The following is a description of a gene set: studied in species Mus musculus Mouse Gene Set: GOMF_SERINE_HYDROLASE_ACTIVITY Catalysis of the hydrolysis of a substrate by a catalytic mechanism that involves a catalytic triad consisting of a serine nucleophile that is activated by a proton relay involving an acidic residue (e.g. aspartate or glutamate) and a basic residue (usually histidine)., and this is the list of marker genes: Itih5, Itih4, Tmprss11a, Ctsa, Spink5, Masp2, Cela3b, Serpinb1a, Klk1b24, Tpp1, Serpini1, Gzmc, Wfdc18, Klk9, Serpine3, Serpinb9c, Cma1, Serpina3j, Prrg4, Adam17, F3, Clpp, Pcsk1, Dpp8, Col6a3 (NCBI Gene Id 98389), Serpinb5 (serine (or cysteine) peptidase inhibitor, clade B, member 5), Aplp2, Wfdc12, Serpinb9f, Ubac2, C1s1, F2, Klk1b16, Rhbdd2, Mbtps1, Sec11c, Pbp2, Proz, Serpinb3b, Sec11a, Pcsk9, Prss30, C1rl, Klk1b22, Wfikkn1, Cfd, Prss44, Agt, Rhbdf2, F7, Rhbdd3, Serpine1, F12, Prss3, Prss16, Wap, Cfi, Serpina3m, Serpina16, Klk1b1, Klk1b27, Lonp2, Tmprss7, Pebp1, Klk1b9, Serpina1c, Serpinb9b, Slpi, Wfdc21, Prss2, Serpinb11, Rhbdd1, Serpina3i, Prss27, Spink6, Habp2, Tmprss11d, Serpinb9g, Klk11, Wfdc3, Tmprss11e, C1ra, Tmprss9, Prss21, Prss59, Ltf (lactotransferrin), Prss35, Wfdc11, Serpina1f, Cpvl, Gzmk, Rhbdl1, Serpinb7, Parl, Spink8, Klk1b21, Prrg1, Serpinb1c, Pla2g6, Prss54, F9, Acr, Mcpt1, Mansc4, Ache, Mst1, Wfdc5, Spint4, Serpina3f, Rhbdl3, Scpep1, Prep, Tysnd1, Gzma, Serpina3k, Elane, Gzmn, Prss28, Reln, Serpinb3c, Rhbdf1, Prrg2, Hrg, Prss32, Prss42, Pcsk5, Tmprss12, Immp1l, Tmprss6, Tmprss11b, Spink10, Serpinb6a, Prss12, C1rb, Serpinb3a, 1810009J06Rik, Prss39, Prss45, Serpina1d, Prss33, Serpinb13, Tmprss11f (NCBI Gene Id 243083), Itih3, Gzmg, Ctrc, Serpina3g, Spink13, Itih2, Papln, Tpsg1, Wfdc10 (NCBI Gene Id 634952), Htra1, Serpina3c, Serpina3n, Wfdc15b (WAP four-disulfide core domain 15B), Mcpt9, Prss36, Cela1, Prss43, Klk12, Tmprss5, Prss51, Tmprss11g (transmembrane protease, serine 11g), Cd109, Mug2, Prss8, Prss1, Dpp4, Serpinb2, Klk1b3, Serpinb6e, Tpsb2, Htra3, Prss23, Serpina10, Ovch2, Pcsk6, Plau, Pcsk2, Plat, Aadac (NCBI Gene Id 99574), Wfdc13 (WAP four-disulfide core domain 13), Tpp2, Pcsk4, Prss37, Prss53, Klk8, Serpinb6b, Spint1, Lipe, A2ml1, Wfdc8, Klk1b26, A2m, Prss41, Tfpi, Prss57 (serine protease 57), Prss38, Klk13, Mcpt4, Ctsg, Serpinb9h, Serpina3b, Klk1b4, Prss40 (NCBI Gene Id 21756), Serpind1, Serpinb9 (serine (or cysteine) peptidase inhibitor, clade B, member 9), Serping1, Hp, C2, Prss48, St14, Reck, Htra4, Spink4, Spink11, Wfdc15a, Dpp9, Ctsh, Apeh, Spink2, Try5, Pzp, Proc, Cela3a, Cela2a, Prtn3, Gzmm, Spink1, Cma2, Pcsk7, Wfdc2, Hgfac, Dpp10, Klk4, F10, Serpina3a, Tmprss11c, Try10, Mcpt2, Endou (endonuclease, polyU-specific), Tfpi2, Prss46, Wfdc1, Itih1, Prcp, Klk14, Immp2l, Corin, Mmp9, Serpini2, Klk1b11, Ctrb1, Nup98, Lonp1, Serpinf2, Prss50, Prss3b, Anxa2, Wfdc16, Prss34, Spink7, Serpina9 (serine (or cysteine) peptidase inhibitor, clade A (alpha-1 antiproteinase, antitrypsin), member 9), Serpinh1, Tmprss2, Crim1, Plg, Gzmf, Prrg3, Serpinb10, Prss58, Klk1b5, Serpina6, Mmp8, Spink12, Serpinc1 (NCBI Gene Id 98260), Serpina1a, Gzmd, Spint2, Klk1b8, Try4, Prss22, Serpinb6d, Serpinb6c, Rbp3, Tmprss15, Prss3l, Col7a1, Ace, Rhbdl2, Wfdc6b, Tmprss4, Serpina7, Serpinb8, Serpinb1b, Serpinb12, App, Klk7, Mmp2, Masp1, Prss55, Prss29, Ambp, Serpina1b, Serpinb9d, F11, Klk10, Dpp6, Mug1, Klk1, Dpp7, Spint3, Serpina12, Klkb1, Serpinf1, Wfikkn2, Ctrl, Prepl, Wfdc9, Serpina5, Wfdc17, Hgf, Prss52, Klk6, Fap, Mcpt8, Serpinb9e, C1s2, Tmprss13, Serpina1e, Gzme, Serpina11, Tpsab1, Prss56, Pcsk1n, Htra2, Serpine2, Eppin, Cfb, Hpn, Ctsc, Gzmb (granzyme B), Klk15, Wfdc6a, Gm2663, Klk5, Col28a1, Furin, Prss1l, Tmprss3, Nceh1, Serpinb3d